The following is a description of a gene set: The adhesion of one monocyte to one or more other monocytes via adhesion molecules. species: Mus musculus Mouse Gene Set: GOBP_MONOCYTE_AGGREGATION, and this is the list of marker genes: Has2, Nr4a3, Cfh, Cd47, Bmp7, Cd44, Il1b (NCBI Gene Id 16176), Thbs1